Given this list of marker genes RAN, NUP153, CDC34, SMU1, PSMA2, SLC31A2, FAM20C, SUB1, CDH1, TIMM8A, AEBP2, BRIX1, FDFT1 (NCBI Gene Id 2222), SRSF10, UTP6, TNFAIP8L1 (TNF alpha induced protein 8 like 1), LFNG, PROCR, KRT82, YIF1B, NAA15, ABHD17C, LSM12, TAF10, UBQLN4, NME1, CRELD2, S100A6, NEPRO, MTAP, SLC4A7, PWP1, MAPK1IP1L, STAT5A (NCBI Gene Id 6776), HS3ST3B1, BCCIP, SH3PXD2B, FMNL2, TIMM50, ABCF1, JPT2, SLC12A4 (NCBI Gene Id 6560), CNN3, FASTKD2, LRP8, SAC3D1, PLK3, AGPAT5, PPA1, CUL2, SRGN, IPO7, HIVEP1, NOP56, USP36, UTP4, COX17, GADD45B (NCBI Gene Id 4616), ZNF507, INPP5B, P2RY14, ERRFI1, PSMD7, ERH, SLC2A6, COPS4, SLCO4A1, CRTC3, RGL1, NKRF, TRAF1, DCTD, ALAS1, YES1, KLF9, UCHL3, PRMT3, STRBP, GPR171, SLC7A6, FDPS, DIMT1, THYN1, NMD3, RBM12, GPR85, SRFBP1, CYP51A1, HLA-DRB1, GFER, POLR3E, B3GALT6, NDUFAF4, TGFB1, HSPH1, AARD, TMEM167A, SRC, DDX42 (DEAD-box helicase 42), SLC35B1, ZMYND19, LYAR, ACVR2A, RBM34, PXDC1, IKZF4, RIOX2, SF3B3, KTI12, MED29 (NCBI Gene Id 55588), SUPV3L1, TAF1A, PRDX6 (NCBI Gene Id 9588), EMILIN2, SND1, SIN3B, LCP2, KDM6B, RMDN3, UBTD2, RANBP1, SNRPD3, LIPE, SEMA7A, PRMT5, CCRL2, FUBP1, HERPUD1, ZNF598, BMS1, CMKLR1, UCK2, GAS7, HEATR1, GNB4, ZC3H18, RSL24D1, SOCS1, NOL8, PRPF31, PDIA4, ABCC1, TOP1, FKBP4, CELF4, GFI1, BMP2K, RAB3IL1, SNAP23, SEPTIN11, ODC1, SERPINB2, FOSL2, PRDM1, CZIB, TAF4B, URB2, SPINT1, PIN1, RWDD1, HEMK1 (HemK methyltransferase family member 1), RANBP2, FBRS, KAZN, PLAU, EIF3B, SDE2, PFAS, BATF3, MAGOHB, IFRD2, FNDC3A, BAG2, IL1RN, RCC1L, CSF2RB, LCA5L, UBE2F, CCR7, USP7, COPS8, RARA, LZIC, CCT5, PSMA6, TNFRSF13B, MREG (melanoregulin), EML4, HOMER1, NUBP1, MRPL32, DNAJC21, XPO1, GIMAP5, STC2 (NCBI Gene Id 8614), ATP2A2, PSMA4, PRMT1, TMBIM1, MET, here is a description of the gene set: Human Gene Set: GSE32986_UNSTIM_VS_CURDLAN_LOWDOSE_STIM_DC_UP A simultaneous engagement of different pathogen recognition receptors provides a tailor made adaptive immunity for an efficient defence against distinct pathogens. For example, cross talk of TLR and c-type lectin signalling effectively shapes distinct gene expression patterns by integrating the signals at the level of NF-κB. Here, we extend this principle to a strong synergism between the Dectin-1 agonist, curdlan, and an inflammatory growth factor, GM-CSF. Both together act in synergy in inducing a strong inflammatory signature which converts immature DCs to potent effector DCs. A variety of cytokines (IL-1β, IL-6, TNF-α, IL-2 and IL-12p70), costimulatory molecules (CD80, CD86, CD40 and CD70), chemokines (CxCl1, CxCl2, CxCl3, CCl12, CCl17) as well as receptors and molecules involved in fugal recognition and immunity such as Mincle, Dectin-1, Dectin-2 and Pentraxin 3 are strongly up-regulated in DC treated simultaneously with curdlan and GM-CSF. The synergistic effect of both stimuli resulted in strong IKBα phosphorylation, in its rapid degradation and in enhanced nuclear translocation of all NF-κB subunits. We further identified MAPK ERK, as one possible integration site of both signals, since its phosphorylation was clearly augmented when curdlan was co-applied with GM-CSF. Our data demonstrate that the immunomodulatory activity of curdlan requires an additional signal provided by GM-CSF to successfully initiate a robust β-glucan specific cytokine and chemokine response. The integration of both signals clearly prime and tailor a more effective innate and adaptive response against invading microbes and fungi. species: Homo sapiens from publication Min L, Isa SA, Fam WN, Sze SK, Beretta O, Mortellaro A, Ruedl C (PMID 22250091) Genes up-regulated in bone marrow-derived dendritic cells: unstimulated versus low dose of 1,3-beta-D-oligoglucan.